Given this list of marker genes Hfm1, Fignl2, Rpusd1, Myo3a, Dhx30, Fkbp6, Dct, Top1, Dync1li1, Cwc27, Fkbp11, Cyp2j6 (NCBI Gene Id 13110), Pmm1, P4hb, Kif5a, Ddx47, Kif19b, Cyp2j8, Atrx, Myh1, Gnpda1, Blm, Ptgds (prostaglandin D2 synthase (brain)), Dkc1 (dyskeratosis congenita 1, dyskerin), Fkbp15, Tbxas1, Dsel, Ascc3, Skic2, Eif4h (eukaryotic translation initiation factor 4H), Upf1, Ddx17, Fkbp2, Myh3, Degs1l, Dnah17, Renbp, Cftr, Dnah6, Ddx52 (NCBI Gene Id 78394), Kif11, Chd6, Aqr, Recql, Ercc3, Rad54l2, Dhx32, Dna2 (NCBI Gene Id 327762), Idi1-ps1, Psmc2, Ddx10, Thap4, Galm, Kif22, Ppihl, Top1mt, Eif4b, Kif5c, Kif5b, Erp27, Ppil4, Eif4a1, Dnah5, Kif13a, Eif4a3l1, Kif12, Xrcc5, Pus7l, Ptges3, Fignl1, Pdilt, Rpe65, Snrnp200, Tmx3, Kif26a, Recql4, Myh11, Ddx39b, Supv3l1, Myo1g, Chd7, Kif26b, Kif3c, Echs1, Kif17, Pus3, Mcm2, Rpe, Ddt, Dscc1 (NCBI Gene Id 72107), Helb, Myo3b, Top6bl, Ddx3x, Cyp2j11, Trub1, G3bp1, Hnrnpa1, Ppid (NCBI Gene Id 67738), Anxa1, Ppil6, Kif1b, Cenpe, Txndc5, Ddx4, Isyna1 (NCBI Gene Id 71780), Fbh1, Ddx1, Pdia3, Chd1l, Eif4a3, Ppih, Pif1, Kif1c, Brip1, Tmem86b, Mcm7, Mre11a, Zgrf1, Myo6, Katna1 (NCBI Gene Id 23924), Pgm2, Ddx3y, Pbld2 (phenazine biosynthesis-like protein domain containing 2), Myo1h, Enox1, Dhx29, Ddx55, Kif3a, Gsta13, Ddx59, Setx, Chd9, Psmc1, Gpi1, Kif18b, Kif13b, Rigi, Kif7, Ppil3, Hsd3b3, Ebpl, Ruvbl1, Dhx57, Dnah7c, Ebp, Stard9, Dync1i1, Ddx56, Pdia5, Mif, Ddx20, Eif4a2, Ddx25, Glce, Kif14, Ppil2 (peptidylprolyl isomerase (cyclophilin)-like 2), Hsd3b4, Kif15, Top3a, Smarca5, Smarcal1, Myo9b, Cyp2s1 (NCBI Gene Id 97376), Aip, Trp53, Fkbp9, Srr, Dhx35, Twnk, Spo11, Top2b, Mcm4, Psmc5, Dnah2, Fkbp4, Kifc2, Dnah7a, Myo15a, Dicer1, Tdrd12, Fkbp3, Ddx19a, Rpusd3, Mri1, Hyi, Myo19, Pgm2l1, Polq, Kif20b, Ddx54, Sdsl, Tmx1, Cyp2j5, Rfc3, Ddx42, Pgam2, Dhx58, Cyp2j12, Hltf, Myo1e, Kif1a, Mtrex, Chd4, Idi2, Dhx37, Kifc1, Dnah3, Aipl1, Helz2, Ighmbp2, Myo5b, Hells, Myh15, Hsd3b5, Myo1a, Degs1, Smarca2, Ehhadh, Ep400, Ddx19b, Hsd17b4, Myo1f, Ruvbl2, Qsox1, Dse, Ddx28, Dhx15, Mcm3, Kif6, Gtf2f2, Fkbp1a, Ddx27, Dhx36, Myo1c (NCBI Gene Id 97728), Myo5c, Nktr, Mov10, Wrn, Ddx5, Dnah1, Chtf18, Mmut, Mpi, Ddx21, Pgm1, Chtf8, Ranbp2, Kifc3, Ppif, Tnnt2, L3hypdh, Kif2c (NCBI Gene Id 73804), D1Pas1, Kif24, Ttf2, Myh6, Ppie, Hpgds, Rad50, Kif2b (kinesin family member 2B), Hmgcs1, Smarca1, Pdia6, Fahd1, Ddx39a, Ptges2, Ptges3-ps, Hsd3b6, Itgb3, Fancm, Zranb3, Myo7a, Dhx38, Erp44, Ppia, Kif2a, Pbld1, Chd8, Dnah8, Alox15, Ptpa, Fkbp7, Dync2h1, Dnah10, Dhx16, Ercc6, Myo9a, Lss, Gsta1, Myh14, Kif21a, Kif20a, Fkbp5, Znfx1, Top2a, Top3b, Myh4, Gsta2, Psmc4, Mov10l1, Rtel1, Dnah11, Dnah12, Rad54b, Mcm9, Pin1rt1, Fkbp14, Ddx6, Recql5, Ythdc2, Kif9, Ddx11, Ppwd1, Ddx24, Kif16b, Psmc3, Chd1, Ddx31, Kif3b, Gne, Fahd2a (NCBI Gene Id 76488), Dync1h1, Cyp2j9, Fkbp1b, Fuom, Myh7b, Aloxe3, Wrnip1, Ddx46, Ddx43, Ppib, Ddx50, Pgm5, Ech1, Tpi1, Fign, Rpia, Kif28, Dnhd1, Myo5a, Smarca4, Gnpda2, Myh8, Gale, Myl6, Ddx41, Chd2, Ercc2, Idi1, Kifc5b, Pgm3, Myh10, Qsox2 (quiescin Q6 sulfhydryl oxidase 2), Pmm2, Kif19a, Ppig, Xrcc6, Txndc2, Pdia4, Myo1d, Ppic, Shprh, Chd5, Rfc2, Smarcad1, Rpusd4, Dhx40, Cyp2j13, Ptgis, Kif21b, Pgam1, Spast, Ddx18, Fxr1, Pusl1, Amacr, Ifih1, Katnal2, Kif18a, Kif27, Fkbp10, Eif4a3l2, Dhx8, Hspd1, Rfc5, Creld2, Pdia2, Tdrd9, Sub1 (NCBI Gene Id 20024), Trub2, Gsta5, Ercc6l, Nav2, Mcm8, Acadm, Rfc4, Pin1, Myo1b, Eci2, Ppil1, Myh7, Psmc6, Dhx34, Fkbp8, Hsd3b8, Pin4, Kif23, Ptges, Mcm6, Dhx9, Ddx49, Dhx33, Hsd3b1, Myh2, Helz, Ercc6l2, Pus7, Itpk1, Cyp2j7, Gstz1, Fmr1, Myh13, Myo7b, Pus10, Ddx51, Rad51, Dnah9, Hsd3b9, Bpgm, Myo10, Idi2l, Mcee, Eci1 (enoyl-Coenzyme A delta isomerase 1), Eci3, Rpusd2, Hsd3b2, Creld1, Helq, Actc1, Gfus, Naxe, Dqx1, Dnai2, Dnah14, Mcm5, Yjefn3, Kif4, Katnal1, Dnah7b, Rad54l, Pus1, Myh9, here is a description of the gene set: Mouse Gene Set: GOMF_ISOMERASE_ACTIVITY Catalysis of the geometric or structural changes within one molecule. Isomerase is the systematic name for any enzyme of EC class 5. species: Mus musculus